Given this list of marker genes Pfkfb1, Efemp1, Slc7a1, Arhgap26, Aqp4, Cmss1, Cenpf, Acot1, Noct, here is a description of the gene set: Genes down-regulated in a mouse model of heart disease whose expression reverted to normal by silencing of MIR21 microRNA. species: Mus musculus Mouse Gene Set: THUM_MIR21_TARGETS_HEART_DISEASE_DN from publication Thum T, Gross C, Fiedler J, Fischer T, Kissler S, Bussen M, Galuppo P, Just S, Rottbauer W, Frantz S, Castoldi M, Soutschek J, Koteliansky V, Rosenwald A, Basson MA, Licht JD, Pena JT, Rouhanifard SH, Muckenthaler MU, Tuschl T, Martin GR, Bauersachs J, Engelhardt S (PMID 19043405) MicroRNAs comprise a broad class of small non-coding RNAs that control expression of complementary target messenger RNAs. Dysregulation of microRNAs by several mechanisms has been described in various disease states including cardiac disease. Whereas previous studies of cardiac disease have focused on microRNAs that are primarily expressed in cardiomyocytes, the role of microRNAs expressed in other cell types of the heart is unclear. Here we show that microRNA-21 (miR-21, also known as Mirn21) regulates the ERK-MAP kinase signalling pathway in cardiac fibroblasts, which has impacts on global cardiac structure and function. miR-21 levels are increased selectively in fibroblasts of the failing heart, augmenting ERK-MAP kinase activity through inhibition of sprouty homologue 1 (Spry1). This mechanism regulates fibroblast survival and growth factor secretion, apparently controlling the extent of interstitial fibrosis and cardiac hypertrophy. In vivo silencing of miR-21 by a specific antagomir in a mouse pressure-overload-induced disease model reduces cardiac ERK-MAP kinase activity, inhibits interstitial fibrosis and attenuates cardiac dysfunction. These findings reveal that microRNAs can contribute to myocardial disease by an effect in cardiac fibroblasts. Our results validate miR-21 as a disease target in heart failure and establish the therapeutic efficacy of microRNA therapeutic intervention in a cardiovascular disease setting.